Given this list of marker genes PIGK, MCCC2, CD63, IVD, TMEM108, TMEM150A (NCBI Gene Id 200551), WDR11, PLCB3, TNFRSF12A, ACOT13, PIEZO1 (piezo type mechanosensitive ion channel component 1 (Er blood group)), MIA3, DDX5, TMEM81, DICER1, TBC1D22A, TAF1D, ROMO1, POLR3G, TIFAB, GCC2, UBE3C, PRKD3, CTDSP2, WDR36, GPNMB, ATP5F1A, SPRY2, PICALM, TFDP1, CCT4, ARHGAP22, TMEM70 (transmembrane protein 70), SCARNA17, DDX46, MYO7A (myosin VIIA), CUL7, POLD4, CCNY, MOB3A, HNRNPA0, CHST14, HECTD3, TADA1, BPNT1, LMNB2, HSPA4, RRAGC, NCF2, EEF2, TBC1D5, MAPK3, RALBP1, MBNL3, RCN3, NDUFV1, ZFYVE16, CHD9, PCGF6, QTRT2, CD300LD, DDX51, PGRMC2, HBS1L, RORA, TMCC1, SRM, GPR85, VPS13B, CROT, NPC1, CIBAR1, DCTD, SFT2D2, LAPTM4B, FBXO33, SPECC1, FYTTD1, GDI2, HINT1, CALU, CPSF3, SETD6, BMPR2 (bone morphogenetic protein receptor type 2, NCBI Gene Id 659), PIKFYVE, RNF130, EXTL2, CTDSP1, RYK, PRKDC, TRAPPC2, TMEM87B, CFL1, SAP18, BCKDHA, RAB40C, DBT, IFT74, TPM1, ADCK5, CAPN15, AP2M1, KIF16B, DECR2, MED24, ARPC1B, CPEB1 (NCBI Gene Id 64506), VGLL4, FBLN2, HACL1, MTCL2, GNG2, TOMM40L, FCGRT, NBEAL1, PDGFA, LRRC58, CD24, CMC2, VAT1, E2F3, C6orf62, CORO7, HCFC1, OPHN1, CPOX, B3GNT3 (NCBI Gene Id 10331), PPID, MARCHF7, S100PBP, RPS6KA1, VEGFB, PRKAG2, MARCHF8, LSM2, UMPS, SNORD33, TMEM64, GAB3, PHF14, RASSF3, CCAR2, ABI2, ARID1A, ERRFI1, LPAR6, CXCR2, CTSD, THOC7, SLC20A2, SNX25 (NCBI Gene Id 83891), IPO9, EIF1B (eukaryotic translation initiation factor 1B), NDUFS2, TBCD, PIK3CA (phosphatidylinositol-4,5-bisphosphate 3-kinase catalytic subunit alpha), SELENOF, POLR1B (NCBI Gene Id 88998), SDHC, STAC2, MYL12A, CLYBL, SENP2, CDC42SE2, ADAMTS10, DIP2A, FAM117A, ILF3, LCOR, HSPD1, RNY3, SMYD2, TSC1, KIF23, LAPTM5, RAB1B, CDC16, GALM, IARS2, ELOVL3, DFFA, PI4KB, PDE4D, AKAP9, WIPI1 (NCBI Gene Id 55062), ABCA1 (NCBI Gene Id 8371), here is a description of the gene set: studied in species Homo sapiens Genes down-regulated in Foxp3-Fusion-GFP T conv (FOXP3-): B6 versus NOD background. Human Gene Set: GSE37605_C57BL6_VS_NOD_FOXP3_FUSION_GFP_TCONV_DN from publication Darce J, Rudra D, Li L, Nishio J, Cipolletta D, Rudensky AY, Mathis D, Benoist C (PMID 22579475) The aim of this study was to quantify the impact of chimeric Foxp3-GFP protein on the Treg cell transcriptional program.